Given this list of marker genes STRA6, ADH4, CRABP2, ABCA4, RBP3, OPN5, RBP4, RBP1, CYP2W1, CYP27C1, OPN3, CRABP1, RBP5, RBP7, OPN4, RLBP1 (NCBI Gene Id 6017), RHO, RBP2, ALDH1A2, here is a description of the gene set: species: Homo sapiens Binding to retinal, one of the forms of vitamin A. Retinal plays an important role in the visual process in most vertebrates, combining with opsins to form visual pigments in the retina. Human Gene Set: GOMF_RETINAL_BINDING